The following is a description of a gene set: Reactome Pathway: Cell redox homeostasis The most important response of <i>Mtb</i> to oxidative stress is provided by catalase and peroxiredoxins, both of which get their reducing equivalents through a network of disulfide proteins and, finally, from NAD(P)H. Multiple redundancies make choosing a good drug target difficult. Optimum efficacy can only be expected from inhibitors of the most upstream components of the redox cascades, i.e. the NAD(P)H-dependent reductases TrxB and Lpd (Jaeger & Flohe 2006). part of: Latent infection - Other responses of Mtb to phagocytosis species: Homo sapiens, and this is the list of marker genes: dlaT, trxA, trxB, tpx, ahpC, fgd1, lpdC, trx-2, ahpD